The following is a description of a gene set: Any process in which a host organism stops, prevents, or reduces the frequency, rate or extent of viral transcription. Mouse Gene Set: GOBP_NEGATIVE_REGULATION_BY_HOST_OF_VIRAL_TRANSCRIPTION studied in species Mus musculus, and this is the list of marker genes: Ccl5, Ccl3, Pou2f3, Zfp639, Rest, Jun, Hmga2 (high mobility group AT-hook 2), Tfap4, Hdac1, Inpp5k, Brd4, Tardbp